Given this list of marker genes SNORD118, SLC20A2, ERCC6, PDGFRB, PDGFB, ERCC8, MYORG, here is a description of the gene set: Human Gene Set: HP_CEREBELLAR_DENTATE_NUCLEUS_CALCIFICATION species: Homo sapiens Pathological deposition of calcium salts in the dentate nucleus of the cerebellum. Cerebellar dentate nucleus calcification